Given this list of marker genes Acox3, Acaa1b, Decr2, Slc27a2, Ehhadh, Acot4, Abcd1, Hsd17b4, Eci2, Crot, Acot8, Amacr (NCBI Gene Id 17117), Acox2, Mlycd, Acbd5, here is a description of the gene set: This event has been computationally inferred from an event that has been demonstrated in another species.<p>The inference is based on the homology mapping from PANTHER. Briefly, reactions for which all involved PhysicalEntities (in input, output and catalyst) have a mapped orthologue/paralogue (for complexes at least 75% of components must have a mapping) are inferred to the other species. electronically inferred by orthology from the curated human pathway part of: Fatty acid metabolism Reactome Pathway: Peroxisomal lipid metabolism studied in species Mus musculus